Given this list of marker genes Cyba, Sod2, Prdx5, Prdx3, Gpx8, Cycs, Gstp1, Ncf2, Ccs, Gpx3, Gpx1, Txn1, P4hb, Ncf1, Prdx1, Gpx6, Ero1a, Gpx7, Nox4, Txnrd2, Nudt2, Txnrd1, Gpx2, Sod3, here is a description of the gene set: part of: Cellular response to chemical stress This event has been computationally inferred from an event that has been demonstrated in another species.<p>The inference is based on the homology mapping from PANTHER. Briefly, reactions for which all involved PhysicalEntities (in input, output and catalyst) have a mapped orthologue/paralogue (for complexes at least 75% of components must have a mapping) are inferred to the other species. studied in species Mus musculus Reactome Pathway: Detoxification of Reactive Oxygen Species electronically inferred by orthology from the curated human pathway